The following is a description of a gene set: Human Gene Set: HP_HYPERPLASIA_OF_MIDFACE Hyperplasia of midface Abnormally anterior positioning of the infraorbital and perialar regions, or increased convexity of the face, or increased nasolabial angle. The midface includes the maxilla, the cheeks, the zygomas, and the infraorbital and perialar regions of the face species: Homo sapiens, and this is the list of marker genes: STRADA, COL9A1 (collagen type IX alpha 1 chain), SPART, NSMCE2, IRX5